Given this list of marker genes Mb (NCBI Gene Id 223670), Rac1, Med1, Hdac6, Sp3, Tspo2, Diaph3, Cebpg, Nemp1, Trim58, Maea, Bloodlinc, Dnase2a, Sp1, Rb1, Rac2, Id2, here is a description of the gene set: Mouse Gene Set: GOBP_ENUCLEATE_ERYTHROCYTE_DIFFERENTIATION The process in which a myeloid precursor cell acquires specialized features of an erythrocyte without a nucleus. An example of this process is found in Mus musculus. species: Mus musculus